Given this list of marker genes RMEL3 (enriched in melanoma 3), CRH, NTF3, CHRNA2, RPL21P25, ENSG00000227496, LINC02174, CPNE4, SH2D5, FSHR, LINC01654, OVCH2, SYNE4, NTS, PTPN3, LINC01107, SAMD5, DMKN, CRTAC1, PYDC2-AS1, RNF220, HPSE2, LINC01976, LINC00868, LINC02687, BDNF (NCBI Gene Id 627), OPRK1, SLC17A6-DT, TMEM215, HACD1, SYNPO2, GLB1L3, HSD11B2, PROX1-AS1, here is a description of the gene set: Marker genes curated from the annotated cluster as represented in the Descartes Human Gene Expression During Development database. species: Homo sapiens The gene expression program underlying the specification of human cell types is of fundamental interest. The study authors generated human cell atlases of gene expression and chromatin accessibility in fetal tissues. For gene expression, the study authors applied three-level combinatorial indexing to >110 samples representing 15 organs, ultimately profiling ~4 million single cells. The study authors leveraged the literature and other atlases to identify and annotate hundreds of cell types and subtypes, both within and across tissues. Our analyses focused on organ-specific specializations of broadly distributed cell types (such as blood, endothelial, and epithelial), sites of fetal erythropoiesis (which notably included the adrenal gland), and integration with mouse developmental atlases (such as conserved specification of blood cells). These data represent a rich resource for the exploration of in vivo human gene expression in diverse tissues and cell types. Human Gene Set: DESCARTES_FETAL_CEREBRUM_LIMBIC_SYSTEM_NEURONS from publication Cao J, O'Day DR, Pliner HA, Kingsley PD, Deng M, Daza RM, Zager MA, Aldinger KA, Blecher-Gonen R, Zhang F, Spielmann M, Palis J, Doherty D, Steemers FJ, Glass IA, Trapnell C, Shendure J (PMID 33184181)